Given this list of marker genes RANBP1, HK3, LNPEP, PSMD3, BMP2K, GTF2H5, EXOSC9, PELO, NUP155, IFI35, TYMS, CCL4, AURKA, CENPF, PPM1G, MAD2L1BP, CKS2, PTGIR, TUBB, SLA, NEK2, BUB1, BLTP3B, FOSL1, KLHL4, TJP2, ATP5F1B, NGDN, GFI1, IFNA6, PAK1IP1, MSMO1, TUBB6, COQ2, FLOT1, PBK, GSTT1, FOXM1, SNRNP25, PMAIP1, GNLY, TIPIN, COX8A, CKS1B, PSMD6, GRPEL1, MZB1, HBEGF, BUB1B, PSMD12, SAP30, ERCC2, MRPS34, MYO5A, PSMA2, MTHFD2, EOLA2, PKP4, TSPAN3, NOP10, CDK7, C19orf53, ORC6, SLC43A3, PRF1, MAN1A1, SEC13, IPPK, RPN1, CCNH, PPCDC, ACSL3, GOLT1B, CHEK2, ANXA4, DCTN5, IL10 (NCBI Gene Id 3586), LBHD1, LAP3, NCAPG, MRPL23, MPDU1, TMEM33, PHB1, QPRT, BTG3, TBC1D31, MFAP1, JOSD1, BLM, PSMD11 (proteasome 26S subunit, non-ATPase 11), PIR, SLC25A11, UBE2M, NFIL3, PHLDA1, LAG3, UFC1, PYCR1, MTCH2, NASP (NCBI Gene Id 96573), EMC1, MYDGF (myeloid derived growth factor), YARS1, HPGD, SEC61G, KCTD9, AKR1B1, FANCG, CDK4, BIRC5, CNP, CDKN1A, TMEM70, MRPL13, ANXA3, APOL1, POGLUT2, GSTZ1, ELOVL6, KIF18A, SLC35F5, PSMB5, RNASEH2A (NCBI Gene Id 10535), DBN1, RAD54B, PLA2G4C, MTHFD1 (NCBI Gene Id 4522), SPOCK1, ATP2A2, TMEM208, IDH3G, WARS2 (NCBI Gene Id 10352), SERPINB1, PSMB2, ASCC3 (NCBI Gene Id 63921), SMC2, DPY19L1, ARL3, RRM2, FAH, YIF1A, LGALS1, GMNN, RAD23B, ENTREP3, RAB5IF, APOD, POLE2, NINJ1, CD200, SLC25A44, IL2RA, IL22, EIF4G1, TMEM97, CCNB2, H2AC4, KNTC1, STMN1, ATP5MC1, CYB5R4, APOBEC3G, PPP4C, PSMB10, BRCA1, CEBPG, SLC7A5, IDI1, MRPL12, WAPL, AP4S1, NSD2, PDK3, ACOT7, GGH, VCP, UBE2K, BST2, WDR74, FTH1, DDX41 (NCBI Gene Id 96647), DLGAP5, ESPL1, SYT11, TIMELESS, HTRA2, RASSF1, CD59, STK3 (serine/threonine kinase 3), TNFRSF4, MANF, SNRPB, NDUFV2, WIPI1, NFE2L3, FES, PTTG1, SDF2L1, ERGIC2, here is a description of the gene set: Human Gene Set: GSE3982_CENT_MEMORY_CD4_TCELL_VS_TH1_DN species: Homo sapiens In the present study we used Affymetrix oligonucleotide microarrays to produce gene transcription profiles for the major leukocyte types in humans. This comprehensive dataset enabled us to not only establish which genes were expressed in each leukocyte type, but also which genes were expressed in each subset after activation. The used of a comprehensive dataset of gene profiles from all the major human leukocyte subsets enabled a novel and powerful means for identification of genes associated with single leukocyte subsets, or different immune paradigms. from publication Jeffrey KL, Brummer T, Rolph MS, Liu SM, Callejas NA, Grumont RJ, Gillieron C, Mackay F, Grey S, Camps M, Rommel C, Gerondakis SD, Mackay CR (PMID 16474395) Genes down-regulated in comparison of central memory CD4 T cells versus Th1 cells.